Given this list of marker genes GREM1, APC, MLH1, COL14A1, BMPR1A, SMAD4, MSH2, AAGAB, NTHL1, here is a description of the gene set: Adenocarcinoma of the small intestine Human Gene Set: HP_ADENOCARCINOMA_OF_THE_SMALL_INTESTINE A malignant epithelial tumor with a glandular organization that originates in the small intestine. studied in species Homo sapiens